Given this list of marker genes DYRK2, TNNI1, LDHAL6B, RABL6, SIN3A, PUM2, AKNAD1, SOX14, GNL3LP1, H2AJ, TNFSF12-TNFSF13, CNTLN, DNAJC7, ZNF217, LUC7L3, INO80, LUZP1, SLC13A1, MAPKAPK5, SRSF8, PCGF1 (polycomb group ring finger 1), PTGER2, PBRM1, SRPK1 (SRSF protein kinase 1), TMBIM6, DCDC1, ZBTB47, TM9SF2, SARNP (NCBI Gene Id 84324), CORO2A, HDAC9, LHX5, ORC1, GK, TNRC6A, SORBS2, RHEB, PRM1, GARIN1B, SLC9A9, MSTN, BTK, LMOD1, ARHGAP30, KMT2D, AP2B1, SNX2, PDYN, C2CD4A, BHLHE22 (NCBI Gene Id 27319), MTF1, ZNF654, PPP1R3D, MAP4, FAM217B, SDHAF2, SLC22A2, EPHA2, SOS2, MAPKAPK5-AS1, FA2H, SH3BGRL, LHFPL1, MAP2K5, ANKRD54, SULT2A1, KRIT1, HOXC6, SLC22A17, SMAD1, RPL28, HSD17B2, GASAL1, ANGPT1, NOL4L, SLC12A1, RAPGEF6, PHOX2B, PPARGC1A, TMEM62, TMEM196, EPN1, SYNCRIP, TMEM37, EPHA7, RBFOX1, THG1L, FBRS, NRXN3, PRPF38B (NCBI Gene Id 55119), DENND2D, HOXA2, GAP43, GPRC6A, TEK, KLHL3, NT5C3B, ANKRD2, NKX2-2, GJD4, ELAVL2, PRPF38A, SUPT16H, HCN4, PCDH9, RPA3, NEO1, EPB41L4B, CCDC191, USP54, ITGB8, TOM1L2, SKP2, MANF, NR2F1, MYLK, ANKRD55, PRKAG1, NKIRAS2, SH2D3C, ATRNL1, LIF, GRIA3, UFC1, DLL4, SYNRG, SLC25A25, CAPRIN1 (NCBI Gene Id 4076), ELMO1, FST, TGM5, SGK2, MST1R, TSPAN5, SCN3B, ZFYVE26, SMOC1, DST, DMD, MBNL1, IGSF22, PTCH1, DCAF6 (NCBI Gene Id 55827), WFIKKN2 (WAP, follistatin/kazal, immunoglobulin, kunitz and netrin domain containing 2), PMEL, KCNJ2, ZNF575, ACKR3, CAMSAP1, FAM180A, PITX2, PDIA5, TFDP2, NDST2, PURA, YAP1, NBEA, MAPK3, ZNF541, KLHL10, SHH, HECTD4, ACSM3, UGGT1, UBR5, LRRK1, ID1, CPSF7, VPS45, GZF1, PDZD7, NNAT, QTRT2, RUSC1-AS1, UBALD2, CSMD3, BNC2, OLA1, PPP2R2B, KCNMB1, GDAP1L1, FRMD5, TBL1X, RBBP6, CD34, KRTAP8-1, LLGL2, NOC3L, TIAL1, CITED1, FGA, NPM3, MLX, SPATA2, SLC30A2, DRC3 (dynein regulatory complex subunit 3), BEST3, TPM3, LMO1, SREK1, POU2F3, CORO6, DHX40, NR6A1, SIK3, RIMOC1, NRG2, LIPT2-AS1, SLC25A12, H2AZ1, ACTR3, CRY1, ZNF516-DT, HTR4, GOLGA2P5, VAX1, TSPYL2, MEF2C, LDB2, RINT1, ANGPTL2, SLC22A6, WDFY3, JUP, IKZF2, DERL3, C1orf210, FAAP100 (NCBI Gene Id 80233), ARHGAP26, SESN3, PCF11, SEM1, ZNF513, TLK1, PRR35, SUMO4, HOXD3, FOXP2, GJD2, RBM24 (NCBI Gene Id 221662), S100PBP, IP6K2, MTRF1L, HOXA3, SEZ6, UBE2D3 (ubiquitin conjugating enzyme E2 D3), PLA2G2F, RPRM, BMP7, GSR, CLEC3A, MID1, PIGV, PYGO2, CASK, DDX17, LRRN2, TNFSF12, BCL2L1, IL2RA, here is a description of the gene set: Human Gene Set: AR_Q6 species: Homo sapiens Genes having at least one occurrence of the motif WGAGCANRN in the regions spanning 4 kb centered on their transcription starting sites. This matches the AR transcription factor binding site V$AR_Q6 (v7.4 TRANSFAC).